The following is a description of a gene set: Human Gene Set: GSE17721_LPS_VS_CPG_16H_BMDC_UP species: Homo sapiens from publication Amit I, Garber M, Chevrier N, Leite AP, Donner Y, Eisenhaure T, Guttman M, Grenier JK, Li W, Zuk O, Schubert LA, Birditt B, Shay T, Goren A, Zhang X, Smith Z, Deering R, McDonald RC, Cabili M, Bernstein BE, Rinn JL, Meissner A, Root DE, Hacohen N, Regev A (PMID 19729616) Genes up-regulated in comparison of dendritic cells (DC) stimulated with LPS (TLR4 agonist) at 16 h versus DC cells stimulated with CpG DNA (TLR9 agonist) at 16 h. mouse primary BMDCs were stimulated with tlr ligands and gene expression changes were profiled on Affymetrix arrays, and this is the list of marker genes: HLA-B, TUT7, AKR1B10, GBP7, ZUP1, NTPCR, TPRA1, SLC22A3 (solute carrier family 22 member 3), PMEPA1, ORMDL1, EPN3, GSAP (NCBI Gene Id 54103), IL15, ZFX, UBR3 (ubiquitin protein ligase E3 component n-recognin 3), RD3, MARCHF5, METTL23 (NCBI Gene Id 124512), CRBN, PCNX1, DNAJC7, FHOD3, ST6GALNAC5, UBR7, SASS6, ZC3H8, SEZ6L, UQCC1, PLAC8, CCDC127, NEUROG1 (neurogenin 1), ITGA4, RSAD2, PCGF1, ZBTB12, OPA3, PEAK1, PSME2, MAP3K5, USP38, AMOT, ATXN7L1, RNPEP, PBDC1, NUP133, CYFIP2, C19orf25, DOCK6, SLC30A1, DPP3, PIGQ, SPRTN, RTL8B, TDRD7 (NCBI Gene Id 23424), RABGEF1, DNAJC12, PLA1A, EDEM1, AMMECR1, PPP1R3A, EMP1, IQGAP2, COL4A5, MRPS11, CARHSP1, WASHC3, IFT172, EYA4, CGGBP1, TASOR2, NCOA1, RUFY3, PTPN2, NOS2, AEBP2, KCNA4, UNK, COL4A2, AUH, PPP1R11, CD40, LAMA4, RASA3, AAGAB, IFNGR2, KLF3, PSMB9, TEFM, NXN, TRIM34, MSX1, TIGD5, CSF3R, TRPM1, CCL13, P2RY14, IFIH1, TMEM199, PDLIM4, LAP3, TPST1, HCRT, CAPZA3, SYNPR, MST1R (macrophage stimulating 1 receptor), MBD3L1, CXCL17, LFNG, NR4A2, TOE1, NUS1, ATP6V1G2, CDKN1A (NCBI Gene Id 1026), FABP4, SLFN12L, HIVEP2, DNAH1, SAMHD1, RBKS, PRDX4, TEX19, PAQR7, HSP90AB1 (heat shock protein 90 alpha family class B member 1), NDST2, HELZ2, NUDT19, C1orf52, ZNF212, MPLKIP, EIF4H, MMP17, PDCD1, MPDU1, SLC29A3, CLBA1, CXCL11, CABP5, GFI1, NKX2-1, FOXRED1, IRF7, PPT2, PSMB8, WEE1, PIGA, SHC3, CDC34, NUDT13, SERPINB4, MRPL54, TRIM21, ASB13, NUDCD1, GOT1, PML, SLC30A7, SLC25A10, ZBTB8A, LRRC8A, RNF149, CYP4B1, MOCS2, MAD2L1, LHB, TOP3A, MAPK10, BATF2, ATAD1, CFLAR, MAPKBP1, SSBP2, BAG3, F10, EIF2B2, SEC22A, IL7R, MANEAL, RAPGEF3, LAIR1, ERCC1, SCYL1, RGS5, SLC25A37, SERPINE2, SPRYD3, WDSUB1, TRAK1, DYNLT1, ZNF277, DPCD, ATP10A, P4HA1, AP3B2, ALDH1A1, TUBB3, MSR1, PPP4R2, BMI1, MAN2A1, WDR43